Given this list of marker genes SPRED2, C6orf120, CAPRIN1, TOP1, SP1, BMI1, GALC (NCBI Gene Id 2581), UBE2Q1, RNF44, CSMD3, CREBRF, ABCD4 (ATP binding cassette subfamily D member 4), HNRNPH2, ARID2, TMEM184B, ATP11C, PPP4R4, NPTN, PUM2, PDE4D (NCBI Gene Id 654081), PIK3C2B, GDA, KPNA3 (NCBI Gene Id 3839), TEAD1, MAGI2, TRIB2, SNX6, SP3, DNMT3A, ZMYM4, TSHZ3, ACACA, GAD2, AGO4, ETV1, IFFO1, SNRNP40, FMR1, AZIN1, RHOA (ras homolog family member A), KIAA1217, SIRT1, CHKA, RNF38, STIM2, GPM6A, STYX, VEGFD, NSMCE4A, ZNF281, RNF220, ILRUN, YTHDC1, RC3H1, CLK1, PPM1A, SMAD7, ASAP2, ARID1A, RBBP6, KCNMA1, ANKS1B, ZEB2, ENY2, CNR1, NLK, DYRK1A, KDM6A, SEMA3C, RFX3, here is a description of the gene set: Genes having at least one occurence of the motif GTATGAT in their 3' untranslated region. The motif represents putative target (that is, seed match) of human mature miRNAs hsa-miR-154* and hsa-miR-487 (v7.1 miRBase). species: Homo sapiens Human Gene Set: GTATGAT_MIR154_MIR487